Given this list of marker genes Ctsh, Cpe, Thop1, Lta4h, Naaladl1, Cpq, Ece1, Mme, Adamts13, Ide, Lnpep, Npepps, Erap1, Tpp1, Ace, Enpep, Anpep, Trhde, Cpa4, Nln (neurolysin (metallopeptidase M3 family)), here is a description of the gene set: Mouse Gene Set: GOBP_PEPTIDE_CATABOLIC_PROCESS studied in species Mus musculus The chemical reactions and pathways resulting in the breakdown of peptides, compounds of 2 or more (but usually less than 100) amino acids where the alpha carboxyl group of one is bound to the alpha amino group of another.